Given this list of marker genes STK4, HRAS, KRAS, RASSF5, NRAS, RASSF1, here is a description of the gene set: Pathway Definition from KEGG: RAS // (RASSF1*+RASSF5) // STK4 Human Gene Set: KEGG_MEDICUS_VARIANT_LOSS_OF_RASSF1_TO_RAS_RASSF1_SIGNALING_PATHWAY Loss of RASSF1 to RAS-RASSF1 signaling pathway. Pathway ID: N00097. Pathway type: Variant. Pathway class: nt06266 Non-small cell lung cancer. species: Homo sapiens